Given this list of marker genes FUT6, FUT4, FUT5, B3GALT2, B3GALT1, ST3GAL4 (NCBI Gene Id 80040), B4GALNT2, ST3GAL6, FUT9, RHD, FUT2, FUT1, ST3GAL3, RHCE, B3GALT5, B3GALT4, FUT7, FUT3, ST6GALNAC6, here is a description of the gene set: Blood group systems biosynthesis studied in species Homo sapiens Human Gene Set: REACTOME_BLOOD_GROUP_SYSTEMS_BIOSYNTHESIS